The following is a description of a gene set: Comparisons of global gene-expression profiles revealed a greater distinction between CD4+ Treg cells and CD4+ conventional (Tconv) T cells residing in abdominal (epidydimal) fat versus in more standard locations such as the spleen, thymus and LN. from publication Feuerer M, Herrero L, Cipolletta D, Naaz A, Wong J, Nayer A, Lee J, Goldfine AB, Benoist C, Shoelson S, Mathis D (PMID 19633656) Genes down-regulated in comparison of lymph node regulatory T cells versus thymus regulatory T cells. Human Gene Set: GSE7852_LN_VS_THYMUS_TREG_DN species: Homo sapiens, and this is the list of marker genes: IRAK1BP1, DUSP10, ZGRF1, CENPL, GNB4, CAP1, RRAS2 (RAS related 2), FAM234B, JADE3, LGALS3, LIG4, CERS6, GP6, LYPLAL1, CRYM, PPIL3, PDS5B, XIST, CFTR, ACOT7, NUCKS1, SLBP, THEMIS, SLIT2, EHD3, PRKAR1A, FAM133B, KPNA2, SLC25A14, PGAM1, ENO2, PLEKHA5, ARHGEF39, FRAT2, PFKM, ARMCX1, CILP, TPI1, ZSCAN29, PPP1R3B, CTSC, PTGR1, FUT8, RGS12, NMNAT1, HSP90AA1, CDC23, PYGL, KIFC1, NMRAL1, TTC5, RYR2, PI4K2B, TADA1, C1orf21, C19orf53, TOLLIP, ARHGAP20, ATRNL1, GPSM2, RFLNB (NCBI Gene Id 359845), KIFAP3, NSF, HEMGN, PCNA, MACO1, GK5, ICMT, MEGF9, WDR70, IRGQ, GZMA, SOX4, NAP1L1, BCL2L13, TDRKH, PDE3B, GOLM2, ZFTA, RPL7L1, CCT2, WDR90, MTF2, LACTB, SKP2, CCNB1IP1, NNT, CEP72, SMC5, CYBRD1, HNRNPAB, PTPRF, NFXL1, THBD, HAL, PRELID2, PPHLN1 (periphilin 1), LDHA, METTL6, STT3B, PCGF5, RAMP3, CXCR4, PADI4, GLIPR1L2, ADCY6 (NCBI Gene Id 23320), EZH2, ID2, NTN4, VCL, SEPHS1, MAMDC4, TCF7, IFITM3, DNAJC12, CADM1, RAD51D, PRKRA, DPCD, HELLS, PAPSS1, PLA2G4F, EOMES, YWHAQ, LIF, KIT, IFT74, TCEAL8, DNAAF5, LMO4, TSPAN6, KCNF1, TEX9, FCER1G, H2BC18, SMARCA5, PARM1, RNF14, PRICKLE1, ST6GALNAC2 (ST6 N-acetylgalactosaminide alpha-2,6-sialyltransferase 2), BEX1, TNFSF8, ARID5B, FIRRE, HEBP1, SUPT16H, PTGFRN, THOC7, CEP131, TMEM87A, AKAP12 (A-kinase anchoring protein 12), PTER (NCBI Gene Id 9317), PEPD, RAB4A (NCBI Gene Id 5867), TLCD2, AP1S3 (adaptor related protein complex 1 subunit sigma 3), KCNK5, NUP50, ANXA2, COMMD7, ATF1 (activating transcription factor 1), HSPD1, CSNK1E, C15orf48, NUSAP1, PCBP1, SLC43A3, LZTFL1, ZC4H2, SMC3, HDDC3, HSD17B7, KDM6A, MACROH2A1, ACTN2, RCBTB2, RAMP1, SSX2IP, ZNF43, MXD1, FYTTD1, ADGRL1, TOP1, CMAS, TBC1D19, IFT57, ZNF667, ASF1B, MYB, ATP6V0E2, PRKAR2B, LRRC52, MCF2L, TGFBR3, ENO1, IGFBP7, EZR, AK3, CPTP, FHL1